The following is a description of a gene set: Mouse Gene Set: GOBP_EPITHELIAL_CELL_MATURATION The developmental process, independent of morphogenetic (shape) change, that is required for an epithelial cell to attain its fully functional state. An epithelial cell is a cell usually found in a two-dimensional sheet with a free surface. studied in species Mus musculus, and this is the list of marker genes: Fem1b, Akr1b1, Kdr, Rfx3, Six3, Cebpa, Esr2, Vegfa, Foxa1, Pgr, Xbp1, Fzd5 (NCBI Gene Id 98335), Bhlha15, Tfcp2l1, Kcne1, Epas1, Cdkn1a, Gdf11, Tmigd1, Kcnma1, Hif1a, Hoxb13 (homeobox B13), Gpat4, Tmem79, Hoxa5, Gata2 (GATA binding protein 2), Gja1, Tgfb1, Tyms